Given this list of marker genes BASP1, NRP1, NEUROG1, DCANP1, TDRD6, SEMA3F, SHH, TDRD1, NRP2, TBXT, FZD5, TDRD5, PCSK6, TDRD7, WT1, FRS2, TDRKH, LAMA5, PLD6, HOXD8, CRIPTO, TIFAB, WNT5A, TASOR, NCKAP1, TBX3, here is a description of the gene set: Human Gene Set: GOBP_BLASTODERM_SEGMENTATION species: Homo sapiens The hierarchical steps resulting in the progressive subdivision of the anterior/posterior axis of the embryo.